The following is a description of a gene set: studied in species Homo sapiens The process in which a cell irreversibly increases in size over time by accretion and biosynthetic production of matter similar to that already present. Human Gene Set: GOBP_CELL_GROWTH, and this is the list of marker genes: MUL1, BMPR2, MAG, SLC9A6, PI16, RB1, L1CAM, ESR2, USP9X, EIF4G1, CDA, P3H1, ZNF639, DIP2B, ACVR1B, RIMS1, SH3BP4, RGS2, MEG3, TGFB1, SERPINE2, TGFB2, KMT2D, DDR1, FN1, RARG, OSTN, RBBP7, IMPACT, CTDP1, PRSS2, RGS4, PRICKLE1, CDKL5, BMP10, SEMA7A, KIF26A, GDF9 (NCBI Gene Id 2661), EDN2, TRPV2, SEMA6D (semaphorin 6D), ZEB2, HDAC6, MIR195, SLC44A4, BRAT1, GDF2, ATAD3A, WASF1 (WASP family member 1), IQGAP1, NDEL1, CSNK2A3, CDKL3, PPP1R9B, TRIM32, VGLL4, SLC25A33, LMX1A, SPHK2, ALCAM, SEMA4D, MUC12, NRN1, SIPA1, NCBP1, SGK3, IGFBP1, EXOSC9, ST8SIA2 (ST8 alpha-N-acetyl-neuraminide alpha-2,8-sialyltransferase 2), KAT7, ADCY10, ARHGEF11, CDKN2D, SGK2, PHB1, SEMA4F, GDI1, DNM2, SDCBP, FOXP1, TMEM108, DSCAM, NPM1, CLSTN1, LHX2, FOXL2, IGFBPL1, MMP14 (matrix metallopeptidase 14), DVL1, NANOS1, LGI1, CHPT1, PPT1, APP, ISLR2, SPP1, PRKCZ, ITSN2, ZC3H12D, CTNNB1, TCHP, RUFY3, CYFIP1, NIN, RAPH1, FSTL4, EPB41L5, EPHA7, CD38, CISH, MAP2, SPART, GAREM2, TP53TG5, TSPYL2 (TSPY like 2), RPS6KA1, RIMS2, IFRD1, ARMC12, ADRA1A, AGT, PPP3CB, BLTP1, SLC39A12, MIR19A, STK11, PARP2, SFN, EIF2AK4, GSK3B, PTPRJ, EAF2 (ELL associated factor 2), WNT5A, FLRT1, HYAL2 (hyaluronidase 2), SMURF1, SPAG6, JADE2, CSNK2A1, LAMTOR2, PSMD10, EPM2A, LAMTOR1, CLSTN3, CCN3, YY1, SFRP1, CYP27B1, PABIR1, CDK5, PAK4, EDN3, AUTS2, SPAG9, CDH4, KIF14, WT1, SUPV3L1, SLIT2, MIR199A1, CDKN2AIP, CPNE5, G6PD, KAZALD1, INO80, EBAG9, PLXNA3, RAB21, SEMA6C, NRCAM, CXCL12, PLXNA4, AURKA, VCL, CRK, ATG16L1, DNPH1, SMAD7, GOLGA4, MIR208A, PDLIM5, IL2, CAPRIN2, CYFIP2, CDH1, BTG1, PUM2, CDKN1A, TRIM40, SLITRK1, CAMK2D, NPR1, JADE1, MAP1B, TOMM70, ITCH, NPPB, H3-3A, SYT1, TNFRSF12A, SMAD3, DCC, URI1, DNAJB2, BDKRB1, ADNP, CDC42, LPAR3, IGFBP3, DISC1, SCGB3A1, ADAM10, RND2, ITGB1, CIB1, SLC9A1, CACNG7, EDN1, WFDC1, SESN1, TTL, NLGN3, CFL1, RNF6, AKAP6, FRZB (NCBI Gene Id 2487), MTPN, ACVRL1 (activin A receptor like type 1), RICTOR, PRKCQ, ING1, COBL, SPG11, MAD2L2, NRG3, KDM2B, GJA1 (NCBI Gene Id 7953), ADIPOR1, PAPPA2, TWF2, FLRT3, NPR2, ENO1, CEACAM1 (CEA cell adhesion molecule 1), TNC, SH3GL2, PAK1, EDNRA, ULK2, IGFBP7, RASAL1, SEMA5B, MIR23A (microRNA 23a), SSNA1, CD2AP, CPNE6, MEX3C, LAMB2, NTRK3, RAB33B, NPPA, PLAA, PAK6, MIR19B1, MSX1, NRP1, ULK1, HBEGF, HYAL1, LIMK1, EXOSC4, HSPA1A, IGF1, EGFR, CCDC85B, BAP1, CDC73, CREB3, BCL11A (BCL11 transcription factor A), MAP3K13, DAB2 (DAB adaptor protein 2), NET1 (NCBI Gene Id 10276), SEMA3G, MYOCD, SPG21, PRDM11, CPNE9, UNC13A, CDK11A, ADAM15, NAIF1, N6AMT1, CRABP2, INHBA, GATA4 (GATA binding protein 4), EGLN2, ROS1, TRIM46, FGF13, RPS6KA3, DCSTAMP, TGFBR1, IP6K2, RASGRP2, SMAD4 (NCBI Gene Id 4089), YAP1, RYK, IL17RB, MYL2, SGK1, DERL2, MEAF6, SYT3, TMEM97, GSK3A (NCBI Gene Id 2931), H3-5, ITGA4, CLASP2, PRKG1, PSRC1, HDGFL2, IST1, AVPR1A, BDNF, SOCS2, ST7L, BIN3, MIR24-1, SMARCA2, RGMA, EXOSC2, IGFBP5, OSGIN2 (oxidative stress induced growth inhibitor family member 2), FAM107A, EFNA5, MFSD2A, NTN1, LTBP4, MELTF, ADAM17, S100A9, SYT14P1, CDK11B, CRYAB, SESN2, SYT2, AVP, BCL6, DCUN1D5, BRCA1, SLC23A2, TGFBR2, IL9, PTCH2, TFRC, OLFM1, SPOCK1, EPHX2, TAF9B, CTTN (NCBI Gene Id 2017), PRKN (parkin RBR E3 ubiquitin protein ligase), MEIS1, NEDD4L, TMEM196, MINAR1, LLPH (LLP homolog, long-term synaptic facilitation factor), MAPKAP1, MACF1, RNF157, RPTOR, PRMT2, C9orf72, ENPP1, MLST8, EXTL3, SPHK1, ABL1, CXCL16, XBP1, AGTR1, SIN3A, TEAD1, EXT1, ZFYVE27, CEP43, NGF, EIF4G2, ING4, HNF4A, GNG4, DCLK1, DACT3, AGTR2, CDHR2, CDKN2A, SRF, TRPC5, SOX9, COL14A1, TAOK2, BARHL2, KIAA0319, SEMA3F (NCBI Gene Id 7868, semaphorin 3F), TSG101, EMX1, POSTN, MIR199B, SERTAD3, CGRRF1, APOE, RTN4, TSC22D4, SORBS2, HRG, ANAPC2, ARHGAP4, DCBLD2, POU4F2, SYT4, KRT17, POU4F3, BCL2 (BCL2 apoptosis regulator), S100B, TNN, SEMA5A, NRN1L, PML, KLHL22, CRLF3, CYBA, RERG, S100A8, MAP2K5, NUBP1, SMARCA4, INS, SLIT1, BCAR1, BST2, NDN, MEGF8, CRKL, TNR, MTOR, HSPA1B, CPNE1, DCUN1D3, FHL1, RTN4R, DDX3X (NCBI Gene Id 730543), DRAXIN, CDKN2C, EI24, PAFAH1B1, SYT17, C8orf44-SGK3, SEMA3A, H3-3B, NDRG3, SLIT3, CRYAA, FBP1, SERTAD2, SFRP2, HPN, VEGFA, ING5, OSGIN1, CAV3, IGFBP4 (NCBI Gene Id 3487), DCAF13, ACSL4, JADE3, PPARD, TP53, ERBB2, ARIH2, SOX17, UCN, WNT3, DDX49, OGFR, MAPT, WNT3A, PRR5, NME6, MT3, PLXNA1, CCAR2, PPARA, PAK5, AKT1, NRP2, CDKN1B, F2, SHTN1, PTPRS, NRG1, RACK1, NKX6-1